Given this list of marker genes EGR1, EGR2, FOS, FOSB, JUNB, JUN, EGR3, KLF2, REL, here is a description of the gene set: Human Gene Set: CHASSOT_SKIN_WOUND P27kip is a key inhibitory protein of the cell-cycle progression, which is rapidly downregulated in early G1 phase by a post-translational mechanism involving the proteosomal degradation. In this study, using a wounding model that induces cell-cycle entry of human dermal fibroblasts, we demonstrate that p27mRNA is downregulated when cells progress into the G1 phase, and then it returns to its basal level when cells approach the S phase. By using a quantitative polymerase chain reaction screening we identified inhibitors of differentiation (Id3), a bHLH transcriptional repressor, as a candidate mediator accounting for p27 mRNA decrease. Id3 silencing, using an small interfering RNA approach, reversed the injury mediated p27 downregulation demonstrating that Id3 is involved in the transcriptional repression of p27. Reporter gene experiments and a chromatin immunoprecipitation assay showed that Id3 likely exerts its repressive action through ELK1 inhibition. By inhibiting early p27 downregulation, Id3 depletion blocked (i) the G1-phase progression as assessed by the inhibition of pRb phosphorylation and p130 degradation and (ii) the G1/S transition as observed by the inhibition of cyclin A induction, demonstrating that p27 mRNA decrease is required for cell proliferation. Apart from its effect on the early p27 diminution, Id3 appears also involved in the control of the steady-state level of p27 at the G1/S boundary. In conclusion, this study identifies a novel mechanism of p27 regulation which besides p27 protein degradation also implicates a transcriptional mechanism mediated by Id3. from publication Chassot AA, Turchi L, Virolle T, Fitsialos G, Batoz M, Deckert M, Dulic V, Meneguzzi G, Buscà R, Ponzio G (PMID 17404577) List of the transcription factors up-regulated 1 hr after wounding HDF cells (dermal fibroblasts). studied in species Homo sapiens